The following is a description of a gene set: Mouse Gene Set: GOBP_OXYGEN_METABOLIC_PROCESS The chemical reactions and pathways involving diatomic oxygen (O2). species: Mus musculus, and this is the list of marker genes: Mt3, Fkrp, Fmo2, Nox1, Abcc9, Lipt2, Rnf34